Given this list of marker genes PIP4K2A, NDUFA6, C12orf43 (chromosome 12 open reading frame 43), SEC61G, ZNF475, OAT, TRPV6, ESRRB, LRRC8C, MAP2K6, AKR7A2, OGT, TSPAN15, IFI27L2, NNMT, MPPED1 (metallophosphoesterase domain containing 1), COL9A1, ZWILCH, POLD1 (DNA polymerase delta 1, catalytic subunit), PROKR1, ACACB, PIAS4 (protein inhibitor of activated STAT 4), AIF1L, BCL2L14, HNRNPUL2, IFRD2, SH3BP4, MAP1A, CNTNAP2, RAP1A, E2F2, SIK1, HYPK, MNS1, E2F4, LY75, KDF1, TRAPPC6B, PLAG1, CRIP1, THEM6, UQCR10, UCKL1, XRN2, TFF2, CNTROB, SNORD89, LMNTD2, EML5, SAMHD1, FAM163A, CCDC184, PLK4, SFRP1, SPOCK1, BLM, REST, RAPGEF1, NCAPD2, MED12, CDC42EP2, DMRTB1 (DMRT like family B with proline rich C-terminal 1), CA9, RPL18 (NCBI Gene Id 6141), LAGE3, SH3BGRL, GJB1, PUS10, PAK5, USP5, TMT1B, LBH, RNF167, PLIN3, STARD10, LIMK1, TMEM116, ERH, C3orf80, COX17 (cytochrome c oxidase copper chaperone COX17), ME2, FADS2, POLE, CDK1, ZSWIM8, KIF15, GRPR, HES7, SKA1, NARF, TGM2, GPBP1L1, GLS, HNRNPA3, ENSA, SET, CDKN1B, RTN1, RBL1, BFSP1 (NCBI Gene Id 631), CDCP1, E2F8, LAT2, UGT3A2, PLK1, EIF2S3, KRI1, PSMD8, FUT7, CEP83, CCAR2, CENPN, SAMD4B, CCDC71, ATP5PO, FUT9, COMMD5, RPL36A, RINL, DYDC2, SECISBP2, FYN, NWD2, KCTD8, GAL, RANBP1, ABCB8, PLEKHJ1, INSM1, TUSC1, ECT2, PPP4C, GPI, SPTSSA, VRK1, HMG20B (high mobility group 20B), ADGRB2, KLHL26, BCL2A1, DDHD1, HSPE1, LSM5, SIX3, SMN1, GRIP1, NEK8, RASGRP4, MYRF, SLC6A2, RPA3 (replication protein A3), FILIP1L, CLEC1A, COL1A2, MYOZ1, SVEP1, MARVELD3, RPGRIP1, TNFAIP8L1, FSTL3, CEP63, TEX9, SCUBE1, CLCN1 (NCBI Gene Id 1180), PCBP3, KRT72, KRT32, CACNB3 (NCBI Gene Id 784), CENPF, SRY, SSU72, ALOX12B, NACC1, CNOT3, ADD3, ADAMTS9 (NCBI Gene Id 56999), MTMR1, RELL2, NTNG1, DCDC2, ITGB2, SNRPF, FANCG, ABCA2, TMEM52B, JAK3, UGDH, KCTD4, PRC1, ANK1, C1orf21, SLC13A5, S100A10, CORO2A, ARNT2, ABCG4, CORO1B, SNRPD1, MOB3B, TRIOBP, here is a description of the gene set: species: Homo sapiens Genes up-regulated in CD34+ cells treated with GSK-3 Inhibitor IX (BIO) versus those stimulated by BMP4. Human Gene Set: GSE26351_WNT_VS_BMP_PATHWAY_STIM_HEMATOPOIETIC_PROGENITORS_UP Analysis of mobilized peripheral blood CD34+ cells from a healthy volunteer under erythroid differentiation conditions with and without stimulation to the BMP or Wnt signaling pathways. For erythroid differentiation, expanded CD34+ cells were placed in Stemspan SFEM medium supplemented with 2% pen/strep, 20ng/ml SCF, 1U/ml Epo, 5ng/ml IL3, 2uM dexamethasone, and 1uM beta-estradiol. Arrays were performed 2 hours after addition of cytokines. For signaling pathway stimulation, cells were exposed to 0.5uM BIO (a GSK3 inhibitor) for Wnt pathway activation, 25ng/ml rhBMP4 for BMP pathway activation, or vehicle control for 2 hours. Three biological replicates were performed per treatment group. We used microarrays to detail the global program of gene expression changes after Wnt or BMP pathway stimulation in human CD34+ hematopoietic progenitors under erythroid differentiation conditions. from publication Trompouki E, Bowman TV, Lawton LN, Fan ZP, Wu DC, DiBiase A, Martin CS, Cech JN, Sessa AK, Leblanc JL, Li P, Durand EM, Mosimann C, Heffner GC, Daley GQ, Paulson RF, Young RA, Zon LI (PMID 22036566)